The following is a description of a gene set: Genes predicted to be targets of miRBase v22 microRNA hsa-miR-670-5p in miRDB v6.0 with MirTarget v4 prediction scores > 80 (high confidence targets). studied in species Homo sapiens from publication Chen Y, Wang X (PMID 31504780) Human Gene Set: MIR670_5P, and this is the list of marker genes: ARID3B, DUS1L, SLC35A4, SYVN1, NIN, GXYLT1, QKI, GOLGA5, ZNF697, TAF4B, ARID3A, PLEKHA8, BRWD1, SRSF6, IPMK, IRF4, PHF20, ELAVL4, RGL1, YWHAB, SYDE2, NPL, CORO2B, LANCL1, SSTR3, PKIA, BEND6, BAK1, GBP2, CNTNAP1, DDX3X, TMEM135, SEMA4B, HNRNPA3, GPATCH8, PEAK1, FUT4, PPM1H, ABCC4, DLGAP1 (NCBI Gene Id 9229), UBR2, RYR2, CCDC169, M6PR, TOX, PGRMC2, TTPA, INO80D, FGFR2, TMEM72, GP2, FER, EPHA4, ZSWIM6, ALOX5, MFSD14B, CBLL1, ZNF831 (NCBI Gene Id 128611), SCRT2, GRHL1, FAM234B, RALGPS2, QPRT, NRG3, ZFP62, VPS4B, ASXL3, ZMYND11, DOCK3, IER3IP1 (immediate early response 3 interacting protein 1), PROX1, ABTB1, CXCL13, C19orf38, BCL2L2, CCNJL, NEU1, SNX18, TRIM2, TPM4, SLC23A2, LACTB, TMEM237, WNT4 (Wnt family member 4), FAM216B, SLC26A6, RBAK, PDXDC1, CPSF6, TMCC2, APBA1, EHD2, PCDH7, FLG, ZNF704, ZNF148, USP38, LCOR, FBXL19, SUN1, RFX5, SEPTIN6, EDN1, TMEM132E (transmembrane protein 132E), RBM24, ESRRG, DUSP6, LGI2, ANKIB1, ZFP41, IAH1, SLCO3A1, ZNF236, FMO5, ATP2B3, CDH26, SH2B3 (SH2B adaptor protein 3), GRB10, MAP3K3, UBR7, MINK1, LPAR4, ELOVL4, BRWD3, SCN5A, ARHGEF2, AHR, ATG4A, STXBP5L, CER1, RASGEF1A, CCNC, TNFRSF1B, KDM7A, YOD1, CYYR1, FGF14, PI4K2B, AMER2, KDM4C, ANO1, CASZ1, SH3TC2, UNC5C, ZBTB34, PCM1, CECR2, ZBTB37, PHACTR3, NIPAL4, SEC14L2, ENPEP, SRF (NCBI Gene Id 6722), CRB2, PGP, TRIM71, CNNM4, SEL1L, RMND5A, MAP3K11, ATXN7, SP1, MAP3K1, CDH5, FMR1, TRIM5, AGXT2, REL, PPP2CA, SEMA6D, ADAM28, PPP4R3A, PKP4, GLS, ZKSCAN5, BNIP2, ZDHHC9, ITCH, MKNK1, VPS37B, MARK1, LACC1, CBFB, RASSF3 (Ras association domain family member 3), STX6, SLC39A9, BAG4, PDCD4, TRIM59, HOXD1, QSOX2, SPACA1, STARD13, GUCY1A2, DAZAP2, SBNO1 (NCBI Gene Id 55241), CCNJ, NCK2, ZNF396, NUP210, CREM, STIMATE, LRP3, CDKL3, NRXN1, ECE1 (endothelin converting enzyme 1), SLC24A2, GJB7, ADAM9, FAT4, ABCC5, DCP1A, CCR5, ATL2, ARFGEF3, PCNX1, KIF1B, HADHB, SLC17A8, ACVR2A, NAV1, IFT70B, BPNT2, TGFBR1, INTS7, PPAT, NEDD9, SPSB4, ATXN3, PLAGL1 (NCBI Gene Id 5325), CYP24A1, SMAP2, RASA2, ZNF12 (zinc finger protein 12), DLG2, SRGAP2, IRAK1, ZDHHC7 (zinc finger DHHC-type palmitoyltransferase 7), KCNB1, ERMP1, DIPK2A, MEF2D, LFNG, ZNF281, CGN, CARNS1, SS18, PRKRA